Given this list of marker genes Smarca4, Prokr1, Pbrm1, Vegfb, Ace, Fuz, Lrp2, Ctnnb1, Sufu, Hand2, Lrp1, Bmp4, Smad6 (NCBI Gene Id 17130), Arid2, Cplane1, Myh10 (NCBI Gene Id 77579), Sgcd, Setd2, Cfc1 (cryptic, EGF-CFC family member 1), Sec24b, Megf8, Notch1, Gpc3, Dync2h1, Ndst1, Epo, Cntrl, Ap2b1, Apln, Vegfa, Kcnj8, Tgfbr1, Fgf1, Abcc9, Kif7, Mir145a, Robo1, Tbx1, Fgfr2, Snx17, Pcsk5, Epor, Ptk7, Pdgfb, Vangl2, Fgf2, Rxra, Dctn5, Pdgfrb, Prickle1, Mesp1, Dnm2, Tab1, Fgfr1, Gata6, Zbtb14, Aplnr, Plxnd1, Mmp21, Shh, Angpt1, Prok2, Myocd, Spred1, Nppb, Gper1, Srf, Pde2a, Zfpm2, Wt1, Fgf9, Mir143, Ltbp1, Prdm1, Gata4, Apela, Hey2, Tgfbr3, Adamts6, Nrp1, here is a description of the gene set: species: Mus musculus The process whose specific outcome is the progression of the blood vessels of the heart over time, from its formation to the mature structure. Mouse Gene Set: GOBP_CORONARY_VASCULATURE_DEVELOPMENT